The following is a description of a gene set: species: Mus musculus Mouse Gene Set: GOBP_LEUKOTRIENE_B4_CATABOLIC_PROCESS The chemical reactions and pathways resulting in the breakdown of leukotriene B4, a leukotriene composed of (6Z,8E,10E,14Z)-eicosatetraenoic acid having (5S)- and (12R)-hydroxy substituents., and this is the list of marker genes: Cyp4f14, Cyp4f15, Cyp4f18, Cyp4f13, Cyp4f40